The following is a description of a gene set: Mouse Gene Set: GOBP_MITOTIC_CELL_CYCLE_PHASE_TRANSITION The cell cycle process by which a cell commits to entering the next mitotic cell cycle phase. species: Mus musculus, and this is the list of marker genes: Myo16 (NCBI Gene Id 244281), Ube2c, Taok1, Ccne1, Clasp2 (CLIP associating protein 2), Foxo4, Pcid2, Cdkn1c, Trim71, Dpf2, Larp7, Pim2, Cenpe (centromere protein E), Tpd52l1, Ctdsp1, Lsm11, Taf2, Rbl2, Prmt2, Cdca5, Cdc25a, Tjp3, Cables1, Ints3, Nek6, Plrg1, Trex1, Nfia, Ino80, Ptpn6, Phf8, Eif4ebp1, Ccni, Rrm1, Ccng2, Incenp, Appl1, Rrm2, Anapc1, Hspa2, Cdk1, Mta3, Camk2d, Ppp6c, Tmod3, Smarca4, Anapc4 (anaphase promoting complex subunit 4), Ccny, Pten, Zw10, Anp32b, Rab11a, Psme2, Kntc1, Smarcd3, Prpf4b, Ccnb2, Ube2srt, Pkia, Fgf10, Stk35, Ubd, Cdc23, Rad17, Smc5, Wac, Dact1, Cdk2ap2, Cdc20, Spast, Cdk14, Ddx3x, Gen1, Pbrm1, Tfdp1, Anapc2, Id2, Rdx, Spc24, Rpa2, Pkd2, Pkd1, Syf2, Rad51c, Itgb1, Ccnd2, Ccng1, Birc5, Senp2, Pabir1, Gpr132, Aurkb, Calm1 (calmodulin 1), Fzr1, Nbn, Phf10, Calm2, Smarcc2, Cdkn1a, Klhl18, Ccnd3, Fhl1, Knl1, Bcl7b, Mad2l1bp, Rint1, Nek11, Ddr2, Rps27l, Abraxas1, Apex1, Tacc3, Cdc14a, Atad5, Ttk, Acvr1, Nabp1, E2f4, Ccna1, Chmp7, Cdkn1b, Tcf19, Prkcq, Sde2, Etaa1, Inip, Acvr1b, Actb, Chmp2a, Anapc7, Xrcc3, Cep192, Inhba, Cdk5rap2, Anapc15, Chek1, Plk2, Mad2l1, Uimc1 (NCBI Gene Id 77298), Clasp1, Cacnb4, Anapc11, Arid2, Ccne2, Cdc14b, Ankrd17, Crebbp, Ccna2, Usp44, Abcb1b, Ube2e2, Mir26a-1, Zfyve19, Cdkn2c, Rnaseh2b, Hacd1 (3-hydroxyacyl-CoA dehydratase 1), Miip, Pkmyt1, Chfr, Slfn1, Dbx2, Pias1, Nabp2, Ube2u, Cul4b, Id4, Npm2, Cpsf3, Ambra1, Rpl17, Nasp, Ctdspl, Cdc16 (CDC16 cell division cycle 16), Brcc3, Rcc2, Camk2g, Brd7, Babam1, Ercc2, Cdc25b, Jade1, Ppp2r3d, Nae1, Smarcd2, Stil, Topbp1, D1Pas1, Zfp36l2, Psme3, Nuf2, Cit, Lsm10, Zfp655, Aif1, Spdl1, Aven, Rbbp8, Tm4sf5, Cacul1, Cdca8, Cenpj, Arid1a, Rpl24, Ctdsp2, Rfwd3, Ppp3ca, Bard1, Kmt2e, Rad21 (NCBI Gene Id 19357), Arpp19, Hecw2, Babam2, Hspa8, Ccnf, Cenpf, Kcna5, Fbxo7, Rb1, Pdpn, Dync1li1, Kank2, Atr, Rgcc, Ccdc57 (NCBI Gene Id 71276), Arhgap33os, Spc25, Taok2, Khdc3, Gigyf2, Mir124a-1, Ezh2, Neurog1, Gpnmb, Ctc1, Nfix, Brca1, Hinfp, Dcun1d3, Kcnh5, Akt1, Wee1, Riok2, Pdik1l, Ube2s, Ccnh, Creb3l1, Fbxo31, Vps4b, Phb2, Rbl1 (RB transcriptional corepressor like 1), Clspn, Ccnj, Zfp830, Btn2a2, Prkdc, Ndc80, Actl6b, Plk1, Anxa1, Tert, Dpf3, Brd4, Bid, Mdm2, Xpc, Brsk2, Cdk3, Taok3, Trim39, Mbtps1, Ier3, E2f3, E2f5, Lats1, Zfp207, Ptprv, Lats2, Ecd, Cul3, Ticrr, Cdc6, Men1, Brcc3dc, Mastl, Nop53, Lcmt1, Ppp2ca, Actl6a, Tpra1 (transmembrane protein, adipocyte asscociated 1), Mre11a, Psmg2, Rps6, Bub1, Ccnb1-ps, Plk5, Cyp1a1, Smarcc1, Chmp4b (charged multivesicular body protein 4B), Kdm8 (lysine (K)-specific demethylase 8), Usp37, Cdkn2a, Adam17, Ppm1d, Mir26b, Plk3, Eif4g1, Mblac1, Myb, Mbd4, Zwint, Ccnjl, Tex14, Fbxl7 (F-box and leucine-rich repeat protein 7), AY074887, Rad50, Kat14, Eif4e, Cul4a, Eps8, Lmnb1, Cdk6, Foxm1, Donson, Mrnip, Hus1, Camk2a, App, Tfap4, Skp2, Mbtps2, Ddb1, Klhl22, Mir26a-2, Cdk7, Apc (APC, WNT signaling pathway regulator), E2f7, E2f6, Iqgap3, Hus1b, Trip13, Usp22, Psme1, Nfatc1, Nsmce2, Cdc25c, Camk2b, Crlf3, Cdk2 (cyclin dependent kinase 2), Dbf4, Ctdp1, Klf4, Kif14, Zwilch, Bcl7c, Ccnb1, Adamts1, Rhou, Mir124a-3, Dlg1, Pbx1, Rps6kb1, Cdc7, Ppp2r2d, Tgfb1, Tcf3, Usp29, Zfp36l1, Cdk5rap3, Rptor, Smarca2, Atm, Fbxl15, Ush1c, Chek2, Nfib, Hyal1, Cdk4, Rcc1, Sass6, Appl2, Ccl12, Mir124a-2, Smarcb1, Fbxo5, Smarcd1, Bub3, Calm3, Pinx1, Ensa, Dgkz, Plcb1, Mepce, E2f1 (E2F transcription factor 1), Bcl2, Smarce1, Haspin, Sin3a, Ska3, Ercc3, Vps4a, Cdc73, Ccnd1, Dpf1, Taf10, Cdkn2b, Bmyc, Blm, Bcl7a, Dusp1, Dtl, Orc1, Cdc27, Prap1, Zc3h12d, Rrm2b, Ccnb3, Mtbp, Fam107a, Mnat1, Cks2, Gjc2, Mad1l1, Bub1b, Spdya (NCBI Gene Id 75331), Anapc15-ps, Ube2a, Klf11, Egfr, D7Ertd443e, Cks1b, Trp53, Brsk1, Pole, Usp26, Nes, Stox1, Abcb1a, Anapc5, Usp47, Rad51b, Tpr, Foxn3, Ik, Cdkn2d, Chmp4c, Myc, Ska1, Wnt10b, Ccno